The following is a description of a gene set: Any process that results in a change in state or activity of a cell or an organism (in terms of movement, secretion, enzyme production, gene expression, etc.) as a result of a lectin stimulus. A lectin is a carbohydrate-binding protein, highly specific for binding sugar moieties. Mouse Gene Set: GOBP_RESPONSE_TO_LECTIN studied in species Mus musculus, and this is the list of marker genes: Klrc1, Tyrobp, Klri2, Klrd1 (NCBI Gene Id 16643), Klrc3, Clec7a, Klrc2, Syk (spleen tyrosine kinase), Klrk1, Plcg2, Clec4n, Klri1, Klre1